Given this list of marker genes NECTIN1, ATR, EPS8L3, BRF1, SLC1A3, DPH5, HECW2, RIN2, MAN1B1 (mannosidase alpha class 1B member 1), ATP1A2, CLDN1, RPL21, SOX18, GNPTAB, MESD, FLI1, RNU4ATAC, NSUN2, THUMPD1, KDM1A, TMEM147, NIPAL4, DSC3, STAG2, LRP1, LARP7, DSG4, H4C5, GJB6, TCF4, MAPKAPK5, MED12L (mediator complex subunit 12L), PUM1, WNT10A, SMARCA2, CRIPT, ASXL3, B4GALT7, SNRPE, FAM111B, PKP1, TGM1, LZTR1 (NCBI Gene Id 8216), HNRNPK, MAP2K2, RNF113A, EDAR, ADA, ABCA12, NFIB, KRT25, SOS1, DHX30, EBP, RAP1B, CNTNAP2, KDM6A, SOS2, PEX1 (NCBI Gene Id 7788), DNAJC21, RAF1, PRRX1, WDR26, SMS, GTPBP2, NUP188 (NCBI Gene Id 23511), TBX3, DDX3X, HR, KIFBP, IRX5, APCDD1, CDC42, CHD6, KAT5, SPINK5, LPAR6, POLR3A, SF3B4, MBTPS2, VAC14, OTX2, CRELD1, ATAD3A, KMT5B, CCNK, MAP2K1, SPRED2, BRD4, KRT74, LIPN, RAG1, BANF1, ATP1A3, HBA1, ASPRV1, PI4KA, CDH3, STAG1, AARS1, RHOBTB2, SPOP, ALOXE3, TGDS, MARS1, NSD1, H3-3A, LIPH, EDA2R, HERC1, KREMEN1, ITGB6, RNU12 (NCBI Gene Id 574043), SDR9C7, HRURF, LMNA, MEGF8, CDC42BPB, DPH2, HOXC13, WNT10B, SON, MTX2, PIGL, KRAS, FRAS1 (NCBI Gene Id 84949), GJA1, DOLK, PIGK, MEIS2, AASS, LMBRD2, COL3A1, POGZ, MED12, ZMPSTE24, PPP1CB, EDARADD, KRT17, CHST3, SULT2B1, ITGA3, PURA, NF1, FBXO11, UBE3B, EDA, LSS, CYP4F22, IL2RG, KRT71, PEX6, RIPK4, PCNT, MED25, WLS, DNA2, TBCD, KAT6A, ODC1, TTC7A, RBL2, PPP2R3C, DCLRE1C, ST14, HBA2 (hemoglobin subunit alpha 2), CTCF, DLX4, PQBP1, DSP, SHOC2, MAB21L1 (mab-21 like 1), KDF1, UROS, ALX1, NAA10, TRPS1, CEP120, COL11A1, ANAPC1, SIAH1, COG6, BCL11B, JUP, AEBP1, ALX4, USB1, RECQL4, HDAC4, YY1, DPH1, KMT2D, TP63, AHSG, KRT85, KANK2 (NCBI Gene Id 55598), AXIN2, IL7R, CWC27, JARID2, BRAF, WDR35, RPS28, GAD1, RMRP, ALOX12B, RAG2, CDC45, CHD7, LIG4, LTV1, HEPHL1, PLXNA1, TWIST2, FIG4, GJB2, CACNA1A, KDM4B, ANTXR1, here is a description of the gene set: Aplasia/Hypoplasia of the eyebrow species: Homo sapiens Human Gene Set: HP_APLASIA_HYPOPLASIA_OF_THE_EYEBROW Absence or underdevelopment of the eyebrow.